Given this list of marker genes Cebpb (CCAAT/enhancer binding protein beta), Il12a, Tcirg1, Xcl1, Hmgb1, here is a description of the gene set: species: Mus musculus The change in morphology and behavior of a T-helper 1 cell resulting from exposure to a mitogen, cytokine, chemokine, cellular ligand, or an antigen for which it is specific. Mouse Gene Set: GOBP_T_HELPER_1_CELL_ACTIVATION